Given this list of marker genes Camk2d, Cxcr2, Eif5a, Mapk8, Ptpn1, Adcy10, Camk2a, Pten, Agt, Trp53, Igfbp3, Atp2a2, Gata6, Capn2, Tigar, Ltk, Capn1, Smad4, Trem1, Fndc1 (NCBI Gene Id 68807), Bnip3, Casp12, Pou4f2, Mff, Fbxo32, Zfas1, Hmgcr, Map3k5, here is a description of the gene set: studied in species Mus musculus Mouse Gene Set: GOBP_POSITIVE_REGULATION_OF_STRIATED_MUSCLE_CELL_APOPTOTIC_PROCESS Any process that increases the rate or extent of striated muscle cell apoptotic process, a form of programmed cell death induced by external or internal signals that trigger the activity of proteolytic caspases whose actions dismantle a striated muscle cell and result in its death.